Given this list of marker genes HCAR3, ST6GALNAC2, CXCL8, CSF3R, SEMA3C, AOAH, SOD2, FCGR2A, NCF2, CXCR1, CXCR2, FCGR3B, ALPL, here is a description of the gene set: Interferons (IFNs) are cytokines that possess potent anti-viral and immunoregulatory activities. In contrast, their potential role(s) in anti-bacterial defense and neutrophil activation mechanisms is less well explored. By comparing gene expression patterns between immature and mature human neutrophils, we obtained evidence that intracellular proteases and other anti-bacterial proteins are produced at earlier stages of maturation, whereas the genes for receptors and signaling molecules required for the release of these effector molecules are preferentially induced during terminal differentiation. For instance, mature neutrophils strongly expressed genes that increase their responses to type I and type II IFNs. Interestingly, granulocyte/macrophage colony-stimulating factor was identified as a repressor of IFN signaling components and consequently of IFN-responsive genes. Both IFN-alpha and IFN-gamma induced strong tyrosine phosphorylation of STAT1 in mature but not in immature neutrophils. Functional in vitro studies suggested that IFNs act as priming factors on mature neutrophils, allowing the formation of extracellular traps upon subsequent stimulation with complement factor 5a (C5a). In contrast, both IFN-alpha and IFN-gamma had only little capacity to prime immature cells in this system. Moreover, both IFNs did not have significant anti-proliferative effects on immature neutrophils. These data contribute to our understanding regarding changes of gene expression during neutrophil differentiation and IFN-mediated anti-bacterial defense mechanisms. from publication Martinelli S, Urosevic M, Daryadel A, Oberholzer PA, Baumann C, Fey MF, Dummer R, Simon HU, Yousefi S (PMID 15302890) Neutrophil-specific genes down-regulated in comparison of immature with mature neutrophils. studied in species Homo sapiens Human Gene Set: MARTINELLI_IMMATURE_NEUTROPHIL_DN